The following is a description of a gene set: Human Gene Set: GOMF_ANTIPORTER_ACTIVITY species: Homo sapiens Enables the active transport of a solute across a membrane by a mechanism whereby two or more species are transported in opposite directions in a tightly coupled process not directly linked to a form of energy other than chemiosmotic energy. The reaction is: solute A(out) + solute B(in) = solute A(in) + solute B(out)., and this is the list of marker genes: SLC30A2, SLC35E2B, SLC4A11, SLC37A2, SLC4A7, SLC35D3, SLC25A25, SLC9B1, SLC7A8, SLC35E2A, SLC18A3, SLC24A4, SLC24A3, SLC9C2, SLC7A11, TMCO3, SLC30A3, SLC35B3, SLC35D2, SLC35C2, SLC25A4, SLC25A1, SLC25A14, GHITM, SLC35B1, SLC35E4, SLC26A4 (NCBI Gene Id 5172), SLC9A4, SLC25A20 (solute carrier family 25 member 20), CLCN5, SLC25A12, SLC9A1, SLC26A1, SLC4A8, SLC35A1, SLC25A10, SLC30A6, SLC4A5, SLC11A1, SLC25A13 (NCBI Gene Id 10165), SLC24A5, SLC26A2, SLC25A11 (solute carrier family 25 member 11), SLC4A3, SLC18A2, SLC35A5, SLC25A26, SLC35A2, SLC44A1, SLC41A1, CLCN4, SLC9A2, SLC30A9, SLC30A1, SLC26A7, SLC35B2, SLC22A8 (NCBI Gene Id 9376), SLC25A31, SLC25A5, SLC8A2 (NCBI Gene Id 6543), SLC9C1 (solute carrier family 9 member C1), SLC37A3, SLC25A30, SLC44A4, SLC35E3, SLC9B2, SLC25A23, SLC30A8, SLC8A1, CLCN7, SLC26A3, SLC25A16, SLC25A19, SLC7A6 (NCBI Gene Id 9057), SLC4A4, CLCN6, TMEM241, SLC1A5, SLC44A5, SLC47A1, SLC18A1, SLC8B1, SLC25A21, SLC7A13, SLC24A2, SLC35D1, SLC9A5, SLC4A2, SLC9A7, SLC6A4, SLC8A3, SLC41A3, SLC30A5, SLC4A9, SLC37A1, SLC25A2, SLC35A3, SLC17A6, SLC44A2, CLCN3, SLC7A5, SLC30A10, SLC26A9, SLC17A7, SLC24A1 (solute carrier family 24 member 1), LETM1, SLC38A3, SLC37A4, SLC30A4, SLC25A17, SLC32A1 (NCBI Gene Id 140679), CHP1, SLC9B1P1, SLC9A9, SLC26A6, SLC22A6, SLC35C1, SLC7A9, SLC4A1, SLC47A2, SLC38A5, SLC19A1, SLC9A8, UCP2, SLC9A3, SLC25A6, SLC25A24, SLC9A6, SLC26A11, SLC35E1, SLC26A8, SLC22A11, SLC25A15, SLC26A5, SLC4A10, SLC26A10P, TMEM165, SLC18B1